Given this list of marker genes H4C15, H4C11, HDAC1, H2BC3, H4C4, H3C3, H4C16, H2BC13, H4C8, HDAC2, H2BC4, H2AB1, H2BC15, H3C10, H3-3B, H2BC6, GATAD2A, MTA2, H2AC4, H4C13, ERCC6, H4C3, H2AZ2, RBBP4, H4C12, H3C4, H3C12, H2AJ, H3-3A, H3C11, H2AX, H2AC7, H2AC6, H2BC7, RBBP7, H2AC19, TTF1, MTA3, H2BC12, H2AC8 (NCBI Gene Id 3012), H2BC5, H2BC10, H4C14, CBX3, H4C2, H2BC8, H2AC18, H4C9, H2BC12L, H2BC21, GATAD2B, EHMT2, H3C14, H2BC9 (H2B clustered histone 9), CHD3, H3C15, H4C6, H4C5, H3C2, H2BC26, CHD4 (NCBI Gene Id 1108), H2BC17, H2BC11, MTA1, MBD3, H2AC14, H3C1, H4C1, H3C6, H3C7, H3C13, H3C8, H2BC1, H2BC14, H2AC20, here is a description of the gene set: studied in species Homo sapiens ERCC6 (CSB) and EHMT2 (G9a) positively regulate rRNA expression Human Gene Set: REACTOME_ERCC6_CSB_AND_EHMT2_G9A_POSITIVELY_REGULATE_RRNA_EXPRESSION